Given this list of marker genes VPS35L, ROR2, RREB1, JPH2, DPYSL5 (dihydropyrimidinase like 5), PCGF2, FBN1, TBX1, TPM1, NDUFB11, MYH7, GALE, MAP3K7, RPS6KA3, COMT, NXN, COX7B, WASHC5 (NCBI Gene Id 9897), FGFR1, HCCS, FREM1, COL5A2, FLNA, YY1, IDS, PIK3CA, TBX5, CHD7, GATA6, ARVCF, UFD1, KRAS, COL5A1, PLD1, SEC24C, HIRA, MYRF, GP1BB, COL1A1, TMEM260, JMJD1C, MMP21, AGGF1, NONO, FOXF1, CCDC22, CHST14, MYCN, here is a description of the gene set: Any structural anomaly of the tricuspid valve. Human Gene Set: HP_ABNORMAL_TRICUSPID_VALVE_MORPHOLOGY Abnormal tricuspid valve morphology species: Homo sapiens